Given this list of marker genes Crhr2, Crh, Inha, Npvf, Tacr2, Oprk1, Oprm1, Gja1, Inhbb, Ucn2, here is a description of the gene set: Mouse Gene Set: GOBP_NEGATIVE_REGULATION_OF_GONADOTROPIN_SECRETION Any process that stops, prevents, or reduces the frequency, rate or extent of the regulated release of a gonadotropin. species: Mus musculus